Given this list of marker genes MLXIP, SMAD4, SSH2 (slingshot protein phosphatase 2), MTDH, ACSS1, CXXC5, HAGH, ID3, YPEL3, DCAF8, NINJ1, PNPLA7, TEC, STAT6, ZBTB4, DTX1, PACSIN1, NRF1, RNF11, RPLP1, CARD6, RPLP0, DCAF11, KCNMA1, NFKBIE, MPPE1, RPS11, NOCT, LPAR6, RASAL3, CD53, HSD17B11, RFLNB, TRMU, CD6, RPLP2, PAQR7, GPHN, IL17RA, TECPR1, DAPL1, ST8SIA1, GALNT6, ADGRG5, IL16, NXF1, XPC, DCDC2B, TMEM80, JADE2, NPFF, PDRG1, TNIP1, RPL13, MTERF4, RPS15A, TEX264, ABTB3, FAM174B, ITGAE, SCML4, HSD17B8, CCM2, EVL, NR2C1, ACVR1B, RHOF, TIMP2, RAB12, BAZ2B, SMYD3, RPL27A, SPOUT1, CNR2, RPS18, RPS21, RBM6, RPL22, UVRAG, SH3PXD2A, KDM5B (NCBI Gene Id 10765), RPL26, PRKD2, RPS7, RPL36, B3GALNT2, SH3GL1, TMEM108, PIGV, PLEKHG2, UBN1, MED13L, VSIR, CCDC102A, TMEM185A, SLC12A7 (NCBI Gene Id 26129), ZNRF1, OAZ2, TMEM258, TXNDC15 (thioredoxin domain containing 15), UBN2, RPL35, IRF7, TMEM230, SLC14A1 (NCBI Gene Id 6563), TMEM259, SLC6A19, RPS3, ZNF12, UBE2H, ARIH2, USE1, IER5, UBAC2, RPL11, ARRB1, AKAP8L, CERK, CTDNEP1, RPL32, NCOA4, SLC17A9, SLC9A9, RPL17, FAU, RTP4, TCP11L2, RPS14, WLS, IDH2, BTG1, ZFP36, DZIP1, CNGA1, MTURN, RPL38, PCYT2, BACH2, RPS9 (ribosomal protein S9), SLC49A4, FRMD4A, RGCC, PDE2A, LAPTM4B, EEF1B2, SOCS3, IRF2BP2, AGO2, CTR9, SRRM2, SATB1, CDIP1, RNF167, CCDC88B, KLK8, CCR9, FAM120B, UBR2, TRPC4AP, RRAD, SLC16A5, RHOBTB2, APPL2, PPIE, CRTC3, CHST15, BACE1, AMPD1, UBXN11, DSTYK, ZZEF1, TNFRSF1A, ACP6, RPL37A, PKNOX1, ZNF622, RGS14, TENT5A, CD247, SQOR, MLYCD, IL27RA, ENC1, RNF213, RAMP1, RPL19, SH3GLB2, IGFBP4 (insulin like growth factor binding protein 4), ABHD15 (NCBI Gene Id 116236), BMF, PIM2, STX1A, CETN2, C16orf54, RNF123, TNFAIP8L2, DUSP2, LYPD6B, STK4, here is a description of the gene set: Genes up-regulated in comparison of naive vs effector CD8 T cells (4-5 days postinfection). studied in species Homo sapiens Using killer cell lectin-like receptor G1 as a marker to distinguish terminal effector cells from memory precursors, we found that despite their diverse cell fates both subsets possessed remarkably similar gene expression profiles and functioned as equally potent killer cells. However, only the memory precursors were capable of making IL-2 thus defining a novel effector cell that was cytotoxic, expressed granzyme B, and produced inflammatory cytokines in addition to IL-2. This effector population then differentiated into long-lived protective memory T cells capable of self-renewal and rapid re-call responses. Mechanistic studies showed that cells that continued to receive antigenic stimulation during the later stages of infection were more likely to become terminal effectors. Importantly, curtailing antigenic stimulation towards the tail-end of the acute infection enhanced the generation of memory cells. These studies support the decreasing potential model of memory differentiation and show that the duration of antigenic stimulation is a critical regulator of memory formation from publication Sarkar S, Kalia V, Haining WN, Konieczny BT, Subramaniam S, Ahmed R (PMID 18316415) Human Gene Set: GSE10239_NAIVE_VS_DAY4.5_EFF_CD8_TCELL_UP